Given this list of marker genes SLC16A5, SLC7A2, AKR1C4, SLC16A3, SLC12A2, SLC9A6, SLCO1A2, SLC16A1, SLC13A2, ABCG1, SLC16A8, SLC10A1, SLC1A6, SLC16A4, LTBP2, XK, ABCC3, SLC26A3, SLC10A2, SLC22A4, SLC7A5, SLC16A2, here is a description of the gene set: species: Homo sapiens Genes in the cancer module 71. Human Gene Set: MODULE_71